Given this list of marker genes NUFIP2, VCAN, LDLRAD4, ANKRD44, CALN1, CLSPN, ARID5B, NPY, CADM2, ERBIN, EBF1, STON1, C5orf47, TENT5C, NIPAL4, ARID1B, PIM1, SEC24C, RASEF, FBXO47, CACNA1C, B3GALT2, PDGFRA, CDK16, KCNMA1, CPT1A, SLC25A25, SIX4, AHCYL1, DYNC1LI2, SECISBP2L, C12orf50, CPEB2, ANKRD29, HMGA2, MBOAT2, SLC12A5, CROT, POF1B (POF1B actin binding protein), TRIM67, GRIK2, TTC28, YWHAH, MSRB3, CAMTA1, ABCA1, HIPK2, RORA, ZC3H12C, MAPK8, PHACTR2, MAP3K1, SLC39A14, SLC14A1, KMT2E, RIMBP2, SOWAHC, CAMK4, ZNF281, DENND1B, SREK1, GRM8, STS, SAMD8, LDHA, SMARCA5, SLC26A7, HBS1L, ATL2, MEGF10, MAP4K4, SATB2, RAP2A, LRRC19, SEMA3A, CD96, ZBTB34, PHF12, GLCCI1, NAT8, ABHD2, CCNYL1, KIAA1549L, HADHB, EN2, TRIQK, ARMC8, MRPS25, SIRT6, DSC3, HOXC10, HRNR, BACH1, NPC1, SGCB, SLC17A6, PIM3, PNMA1 (PNMA family member 1), SCN8A, DPY19L1, SKI, CDK6, WDFY3, EXPH5, NAA15, ZNF140, INSM1, TMEM86A, SGIP1, LIMCH1, LUC7L3, here is a description of the gene set: studied in species Homo sapiens Genes predicted to be targets of miRBase v22 microRNA hsa-miR-33a-5p, hsa-miR-33b-5p in miRDB v6.0 with MirTarget v4 prediction scores > 80 (high confidence targets). from publication Chen Y, Wang X (PMID 31504780) Human Gene Set: MIR33A_5P_MIR33B_5P